Given this list of marker genes Cav3, Foxp1, Pi16, Pak1, Rgs4, Ctdp1, Rbm10, Zfp418, Tomm70a, Ppara, G6pd2 (NCBI Gene Id 14382), Rgs2, Yy1, Gsk3a, G6pdx, here is a description of the gene set: studied in species Mus musculus Mouse Gene Set: GOBP_NEGATIVE_REGULATION_OF_CELL_GROWTH_INVOLVED_IN_CARDIAC_MUSCLE_CELL_DEVELOPMENT Any process that decreases the rate, frequency, or extent of the growth of a cardiac muscle cell, where growth contributes to the progression of the cell over time from its initial formation to its mature state.